The following is a description of a gene set: Genes predicted to be targets of miRBase v22 microRNA hsa-miR-1257 in miRDB v6.0 with MirTarget v4 prediction scores > 80 (high confidence targets). species: Homo sapiens from publication Chen Y, Wang X (PMID 31504780) Human Gene Set: MIR1257, and this is the list of marker genes: PAN3, MCM9, FOXN3, SPATA6, SLC1A6, H3-5, PRUNE2, GUCY1A2, ARPP19, NDST2, RFX7, TXLNA, BMP4, NRG1, TBC1D12, NT5E, PDE12, CAMK2D, CHST1, RERGL, SCNM1, SMIM13, SPIRE1, UBE2D3, ZNF189, CBLB, CANX, CDK17, XG, TMCC3, SPAG9, TNFRSF21, UBQLN1, ZNF17, MSR1, GCNT1, LILRA1, ZNF519, CIT, GPATCH2L, REP15, CD300E, LYRM2, TFDP1, SERBP1, NDST3, PPTC7, ZNF468, UGT8, H3-3B, KGD4, ATG12, OAZ2, SKA3, DACT3, TMED2, DNAJC6, RGS5, DCAF10, ANO8, GPBP1L1, CEP41, XRCC4, ROBO2, PANK1, TIPARP (NCBI Gene Id 25976), SCN2A, AKAP7, NCAM2, STXBP5L, AKIRIN1, NLGN1, FAM13A, ODF2L, PTPRJ, ENPEP, PHYH, RND1, ZNF781, LATS2, CA10, STIM2, CDC5L, PLAG1 (PLAG1 zinc finger), ZNF41, ERH (NCBI Gene Id 95660), CDKN2A, NAB1, NDN, TRPC5OS, CYP7A1, MYNN, MANSC1